The following is a description of a gene set: Metabolic reactions disrupted by deficiencies of ADA, APRT, HPRT1, and PNP are annotated here. part of: Diseases of metabolism Reactome Pathway: Diseases of nucleotide metabolism studied in species Homo sapiens, and this is the list of marker genes: APRT, ADA, HPRT1, PNP